Given this list of marker genes ADCY5, PRKACA (NCBI Gene Id 5566), ADCY9, FSHB, ADCY2, FSHR, ADCY4, ADCY8, ADCY6, GNAS, PRKACG, PRKACB, ADCY7, ADCY1 (NCBI Gene Id 449484), CGA, ADCY3, here is a description of the gene set: studied in species Homo sapiens FSHR-GNAS-PKA signaling pathway. Pathway ID: N00922. Pathway type: Reference. Pathway class: nt06323 KISS1-GnRH-LH/FSH-E2 signaling. Human Gene Set: KEGG_MEDICUS_REFERENCE_FSHR_GNAS_PKA_SIGNALING_PATHWAY Pathway Definition from KEGG: (CGA+FSHB) -> FSHR -> GNAS -> ADCY -> cAMP -> PKA